Given this list of marker genes BNIP3, POLB, FOXO1, MT-ATP6, CAT, CAV1, HDAC2, MMP2, CYP1A1, SOD2, MT-CYB, FAS, NOX1, COL1A1, ATG7, SLC7A5, TXNRD2, EPO, KCNA5, here is a description of the gene set: Human Gene Set: GOBP_RESPONSE_TO_HYPEROXIA Any process that results in a change in state or activity of a cell or an organism (in terms of movement, secretion, enzyme production, gene expression, etc.) as a result of a stimulus indicating increased oxygen tension. species: Homo sapiens